Given this list of marker genes OSTM1, AREL1, JAK2, RET, LOX, SORL1, here is a description of the gene set: Human Gene Set: ELVIDGE_HIF2A_TARGETS_UP Genes up-regulated in MCF7 cells (breast cancer) after knockdown of HIF2A by RNAi. Studies of gene regulation by oxygen have revealed novel signal pathways that regulate the hypoxia-inducible factor (HIF) transcriptional system through post-translational hydroxylation of specific prolyl and asparaginyl residues in HIF-alpha subunits. These oxygen-sensitive modifications are catalyzed by members of the 2-oxoglutarate (2-OG) dioxygenase family (PHD1, PHD2, PHD3, and FIH-1), raising an important question regarding the extent of involvement of these and other enzymes of the same family in directing the global changes in gene expression that are induced by hypoxia. To address this, we compared patterns of gene expression induced by hypoxia and by a nonspecific 2-OG-dependent dioxygenase inhibitor, dimethyloxalylglycine (DMOG), among a set of 22,000 transcripts, by microarray analysis of MCF7 cells. By using short interfering RNA-based suppression of HIF-alpha subunits, we also compared responses that were dependent on, or independent of, the HIF system. Results revealed striking concordance between patterns of gene expression induced by hypoxia and by DMOG, indicating the central involvement of 2-OG-dependent dioxygenases in oxygen-regulated gene expression. Many of these responses were suppressed by short interfering RNAs directed against HIF-1alpha and HIF-2alpha, with HIF-1alpha suppression manifesting substantially greater effects than HIF-2alpha suppression, supporting the importance of HIF pathways. Nevertheless, the definition of genes regulated by both hypoxia and DMOG, but not HIF, distinguished other pathways most likely involving the action of 2-OG-dependent dioxygenases on non-HIF substrates. from publication Elvidge GP, Glenny L, Appelhoff RJ, Ratcliffe PJ, Ragoussis J, Gleadle JM (PMID 16565084) studied in species Homo sapiens